Given this list of marker genes SMAD2, PLXND1, LRPPRC, MMP21, MAPKAPK5, ZIC3, GJA1, NODAL, GNB2, PLD1, SMARCA4 (SWI/SNF related, matrix associated, actin dependent regulator of chromatin, subfamily a, member 4), CCNQ, NKX2-5, CIROP, MCTP2, TRAF7, DAW1, NOTCH1, here is a description of the gene set: studied in species Homo sapiens An abnormality of the circulatory connection between atria and ventricles. Abnormal atrioventricular connection Human Gene Set: HP_ABNORMAL_ATRIOVENTRICULAR_CONNECTION